Given this list of marker genes Fosb, Jun, Hspa1a, Klf2, Dusp1, Pmaip1, Hspa1b, here is a description of the gene set: Cytokines mediate cell-cell communication in the immune system and represent important therapeutic targets. A myriad of studies have highlighted their central role in immune function, yet we lack a global view of the cellular responses of each immune cell type to each cytokine. To address this gap, the authors created the Immune Dictionary, a compendium of single-cell transcriptomic profiles of more than 17 immune cell types in response to each of 86 cytokines (>1,400 cytokine-cell type combinations) in mouse lymph nodes in vivo. A cytokine-centric view of the dictionary revealed that most cytokines induce highly cell-type-specific responses. For example, the inflammatory cytokine interleukin-1β induces distinct gene programmes in almost every cell type. A cell-type-centric view of the dictionary identified more than 66 cytokine-driven cellular polarization states across immune cell types, including previously uncharacterized states such as an interleukin-18-induced polyfunctional natural killer cell state. from publication Cui A, Huang T, Li S, Ma A, Pérez JL, Sander C, Keskin DB, Wu CJ, Fraenkel E, Hacohen N (PMID 38057668) Genes negatively differentially expressed in cell type: cDC1 (conventional dendritic cell type 1) upon treatment with cytokine: FasL in mouse lymph nodes in vivo. studied in species Mus musculus Mouse Gene Set: CUI_CDC1_FASL_RESPONSE_DN